The following is a description of a gene set: The process whose specific outcome is the progression of the medulla oblongata over time, from its formation to the mature structure. The medulla oblongata lies directly above the spinal cord and controls vital autonomic functions such as digestion, breathing and the control of heart rate. Mouse Gene Set: GOBP_MEDULLA_OBLONGATA_DEVELOPMENT studied in species Mus musculus, and this is the list of marker genes: Cacna1a, Phox2b, Ascl1, Kcne1, Atf2